Given this list of marker genes MDM2, RPL11, NOP53, MRPL18, RRS1, RPL5, TST, RPF2, GTF3A, EEF2, here is a description of the gene set: Binding to a 5S ribosomal RNA, the smallest RNA constituent of a ribosome. species: Homo sapiens Human Gene Set: GOMF_5S_RRNA_BINDING